Given this list of marker genes ESAM, PLTP, CHSY1, GPM6A, SELP, CGNL1, TMTC1, PTPN12, FNIP2, TAGLN2, MYC (NCBI Gene Id 731404), CLDN5, C1QTNF1, CLEC14A, NEDD9, FOSL1, CALCRL, IL1R1, SEC14L1, ARHGAP31 (NCBI Gene Id 57514), TIMP3, BGN, LAMB2, GNAS, SNTB2, AFF1, PLVAP, RAMP2, SULF2, UACA, OAZ2, TFPI, EDN1, FXYD6, FOSB, PNP, ARHGAP23, RHOJ, CDC42EP3, UPP1, KLF3, PREX2, TGM2, ACTN1, NDRG1, SLCO2A1, ITM2B, IGFBP4, CD59, RPGR, PECAM1, HSP90AB1, CD34, PLEC, TMSB10, CRIP2 (cysteine rich protein 2), MIDN, AVPI1, KLF2 (KLF transcription factor 2), SERPINB6, MAST4, CD320, CRIM1, NDRG4, SPTAN1, CTNNAL1, HBEGF (heparin binding EGF like growth factor), CD55, IL6, GJA1, CD9, APP, GPX3, GJA5, FBLN2, AIF1L, NFIB, IGFBP3, JAM2, SYNPO, SASH1, CCL15-CCL14, SERPINE1, OMD (osteomodulin), DPYSL3, SRPX, ITGA5, PTPN14, ARID5B, TUBB4B, SPRY1, ITPKC, LMNA (NCBI Gene Id 7816), IL1RL1 (interleukin 1 receptor like 1), PTGIS, TM4SF1, JMJD1C, MDK, FLOT1, B4GALT5, LTBP4, MMRN1, ADGRF5, EMCN, NFIA, TUBB6, MIR22HG (MIR22 host gene), MYO1C, TIMP1, HYAL2, TIMP2, CYYR1, DKK3, TMEM47, TSPAN7, DOCK9, IL33, SKI, ABI3BP, PTTG1IP, NR2F2, YBX3, TFPI2, EHD2, CYB5R3, C7, TSC22D2, RFX2, STOM, CCN1, PDLIM1, TINAGL1, RFK, DLC1, ID3, LDB2, A2M, TRIOBP, ATP1A1 (ATPase Na+/K+ transporting subunit alpha 1), TGFBR3, FGD5, S100A16, CAV2, ADGRG1, ATN1, DPYSL2, VIM, CD93, CLEC3B, FGF2, ELK3, YWHAE, HSPB1, IGFBP7, SPAG9, NIBAN2, ITM2A, AHNAK, CAV1, GNAI2, NPDC1, CRTAP, RNASE1, EFNB2, ACKR3, PTPRG, CDKN1A, GSN, NASP, B4GALT1, LIMA1, EMP1, S1PR1, ANXA2, FILIP1L, NRN1, AKAP12, LMO2, DOC2B, LRRC32, PLPP1, TSC22D1, INSR, PRSS23, GPRC5A, LIFR, NCOA7, TCF7L1, COL8A1, ST6GALNAC3, MYOF, RAMP3, INPP1, TACC1 (NCBI Gene Id 6867), WWTR1, IFITM3, COL3A1, SPARCL1, PLSCR4, PTGS1, APOLD1, HEG1, ADAMTS4, DSTN (NCBI Gene Id 11034), SERPINB9, IFI6, GARRE1, ANXA1, F8, RSPO3, KCNN3, MYADM (myeloid associated differentiation marker), NOP56, CMIP, NUDT10 (NCBI Gene Id 170685), PDLIM5, CSRP1, RIPOR1, NR2F1 (nuclear receptor subfamily 2 group F member 1), NOLC1, INMT, NOS3, HIF1A, JUND, PTGDS, TIE1, TTC28, ID1, STC1, SPTBN1, FKBP1A, KLF4, SELE, RBMS3, MAFF, MATN2, CCN2, FAM107A, PALM, TP53I11, CAVIN1, IFITM2, ADGRL4, FOXC1, CNTNAP3B, ARL4A, F2R, FILIP1, BMPR2 (bone morphogenetic protein receptor type 2), SOCS3, PTPRB, SPRY4, CAVIN2 (NCBI Gene Id 8436), MGP, ECE1, SWAP70, WARS1, EHD4, ATP1B3, EPAS1, DDX21, TLR4, CD151, THBD (NCBI Gene Id 7056), IFI27, AQP1, VWF, ABLIM1, FLT1, GALNT15, SOX7, FLNB, ADAMTS9, TEK, ITPRIP (NCBI Gene Id 85450), PLPP3, KDM6B, GNG11, ENG, MYCT1, PEA15, PARVA, ADAMTS1, POSTN, LUZP1, C11orf96, HLA-E, CPE, ERG, MECOM (MDS1 and EVI1 complex locus), TNS2, NTS, NOTCH4, TMCC3, S100A10, NFATC1, ASAP1, TPM4 (NCBI Gene Id 7171), NFATC2, BMX, KCTD12, CDH5, MMRN2, PTHLH, DUSP6, TUBA1A, LIMCH1, TCF4, PALMD, BMP4, TSPAN18, PGM5, PKIG, here is a description of the gene set: Human Gene Set: AIZARANI_LIVER_C29_MVECS_2 studied in species Homo sapiens from publication Aizarani N, Saviano A, Sagar, Mailly L, Durand S, Herman JS, Pessaux P, Baumert TF, Grün D (PMID 31292543)